Given this list of marker genes Gjd4, P2rx5, Ppard, Mir675, Myod1 (NCBI Gene Id 17927), Hopx, Spaar, Myoz1, Capn3, Sox15, here is a description of the gene set: Any process that modulates the frequency, rate or extent of skeletal muscle. Mouse Gene Set: GOBP_REGULATION_OF_SKELETAL_MUSCLE_TISSUE_REGENERATION studied in species Mus musculus